The following is a description of a gene set: Human Gene Set: MIR548A_5P from publication Chen Y, Wang X (PMID 31504780) Genes predicted to be targets of miRBase v22 microRNA hsa-miR-548a-5p in miRDB v6.0 with MirTarget v4 prediction scores > 80 (high confidence targets). species: Homo sapiens, and this is the list of marker genes: HOXD13, DNAJB14, DENND1B, RRAGD, ACBD5 (NCBI Gene Id 91452), DHRS1, ZNF608, NOS2, FRMD5, ZDHHC2 (zinc finger DHHC-type palmitoyltransferase 2), PSMC2, TNFRSF21, PREX2, RASGRP1, KLRD1, ZBTB25, HOMER1, THSD7A, PPEF2, RO60, SLU7, ETF1, TTC19, DCDC2, MAML1, SNAP91, CCSER1, MTF1, BTG3, TFAM, RHPN2, ZBTB11, ACAT2, EEA1, MMD, LIN7A, CFDP1, IKBIP, PLEKHH2, ARK2N, ANKRD26, MED6, GULP1 (NCBI Gene Id 51454), SPAG9, FGL2, CCDC117, TMEM200A, GLIPR1, ZNG1F, PDCD5, DTWD2, U2SURP, A1CF, SOX5, CAPN2, CMPK2, SEC24A, AFTPH, CACUL1, ABCA5, LRP1B, AQP3, GPC6, LANCL1, MEX3D, GRIP1, FGF12, TMEM255A, TMEM135, ADAM22, PAX5, FOXG1 (forkhead box G1), NUP54, LATS1, ZNF454, GABRA4, GPD2, IGF1, FZD7, ZNF747 (zinc finger protein 747), MECP2, AGTR1, LARP4, PPP5C, PAQR9, RGPD6, MMP16, ZNF486, ZC3HAV1L, HOOK3, CTNNA3, LACTB2, EPB41L5, EDIL3, MARCHF6, RIMOC1, SFT2D1, TOLLIP, ADAM30 (ADAM metallopeptidase domain 30), HMBOX1, SCAMP1, FYB2, ACVR2B, ACTN4, ITGAV, ODAPH, LRRC7, HNRNPDL, RAB8B, RICTOR, ME1, EXOC5, SAMD8, TXLNG (NCBI Gene Id 55787), PDE1C, B3GALT5, PROK2, METTL6, DUSP7, PRKAG2, CACNA2D3, NR2C1, TRIM9, PRKAA2, SERINC5, MAST3, SRSF3, ATXN7L1, LPP, NDFIP2, CERS6, FGD4, BRWD1, ARFRP1, TMEM65, GCC2, CCDC47, GABPA, CAMLG, TRA2B, CCDC179, UGDH, BBS10, CAMSAP2, SSR3, MDFIC, CLVS2, PRKG1, ERC2, GTF3C3, KCNJ3, RHOQ, URI1 (NCBI Gene Id 8725), TP53INP1, SUMF1, ANKRD46, SIX4, DIAPH3, COL11A1, CEP120, ZBTB20, RNF138, FLRT3, ZNG1E, ZNF326, RBBP8, BTF3L4, PGAM1, KL, CHN1, SPATA6L, SMAD9, WDR7, NUP160, SACS, TRPC5, CSNK1D, C9orf40, UGT8, ZEB2, C21orf91, CCDC50, FAM133A, RC3H1, ELL2, TPM3, RAP1A, RNF149, IGF2BP3, GRID2, MFSD8, OAZ1, BOD1L1, MAP9, PRKAA1, ARMCX3 (armadillo repeat containing X-linked 3), LCOR, ZBTB44, DUS4L, NCKAP1, DPH6, NFKB1, ZRANB2, ZNF148, TMTC1, RORA, SECISBP2L, SESTD1, DEFA6, CHST9, NAA30, SENP1, SRSF6, ZFAND5, APPBP2, CBFB, SPDYE1, LVRN, DYNC1I2, MBNL3, RASSF8, NDC1, ADH5, SREK1, YIPF5, ARL6IP6, TLCD4, SPOCK3, GAPVD1, SNX16, RNF217, FMNL2, MEIS2, HECA, CCNY, HTR2C (NCBI Gene Id 3358), SRP9, AP1AR, HLTF, PRRC1, PRPF39, CLDN12, ZNF559, RGPD4 (RANBP2 like and GRIP domain containing 4), CNTN1, STXBP5, AK3, SANBR, MBNL2, ASB3, KRT28, ATP11A, LCTL, MAST4, GRM5, ZDHHC15, SCN8A (sodium voltage-gated channel alpha subunit 8), ZDHHC21, MMUT, TCF12, PDE4D, DNAJB4, PAPOLG, MAGT1, FNIP2, ZBTB10, ZNF492, DOLPP1, PCLO (NCBI Gene Id 56630), GOPC, RPS6KA5, SLC24A3, MINDY2, SLC4A7, NTF3, FBXL3, STYX, CRIPT, HDAC9, CLCN4 (NCBI Gene Id 4412), CHRNA7, TRUB1, ZNG1B, ACADL, RGS7BP, MTA1 (NCBI Gene Id 9112), ALG11, JARID2, NRG4 (NCBI Gene Id 145957), TMED7, LRRC4B, SERINC3, BNIP3, CD163, MCF2L2, ANGEL2, GUCY1B1, PCDH11Y, MYCN, PRPF40A, ITGB6, TFDP3, PGRMC2, RGPD8, AFDN, PTGFRN, ARID2, DAAM1, PTPRG, SAMTOR, LMCD1 (NCBI Gene Id 29995), HIPK1, GASK1A, GPATCH11, TMEM167B, IGSF3, FAM221A, GNAQ, SDE2, C3orf38, XPNPEP1, ADAMDEC1, GSTCD, SETD2, GPR155, BRWD3, NOTCH2, S1PR1, SLAIN1, RGPD5, TIFAB, CBX3, PPARG, ADGRB3, GABPB1, ZNG1A, AIDA, GRM7, C6orf120, TMTC3, TRPC1, CSGALNACT2, NAT1, IKZF2, ANAPC1, NAV2, UEVLD, PPP1R2, SLCO5A1, PTBP3, GPR85, PIWIL3, CCP110, ZBTB41, FNDC3B, FEM1C, RAB27B, UTP3, CDK6, LACTB, MGARP, ACBD3, DYNC1LI2, MAP4K4, MIDEAS, CD99, UNC80, KLF7, ARL13B (ADP ribosylation factor like GTPase 13B), NFAT5, C5orf24, PRP4K, ATXN2, FZD3, EPHA3, CCNB1, NOTUM, KIF20B, BTG2, NEDD4L, CEP350, NUMB, COMMD3-BMI1, STEAP2, SEC22C, ANKRD22, METTL8, FIGN, RAP2A, NUP50, RIC1, MIER1 (NCBI Gene Id 57708), SCN3A, PRELID2, FSBP, SLC30A5, CFAP44, EIF2AK2, BEND7, CFL2, SDC2, BBX, SCARF1, GOLGA6L2, TRAM1, AHSA2P, RALA, SKIDA1, NRXN1, TBCA, ZNF680, POLR2H, TMEFF2, BCL2L2, ZNF792, ANKRD10, KLF10, RMND5A, PROSER1, PLEKHG1, C11orf87, SCN1A, CARF (NCBI Gene Id 95855), FGFR1OP2, MBIP, MIGA1, SF3A1, MIER3, GCNT1, CIAO2A, SMAD5, SNX30, PDZRN4, PITX2, WDR47, RESF1, SYTL5, ZCCHC8, FAM199X, CRACD, KIAA1586, RETREG1, CYBRD1, SCML2, LSAMP, ADAMTS1, BMI1, SFMBT1, CISD2, KLF8, RFX7, PTPRR, ABI3BP, REV3L, PCDH11X, MFN1 (mitofusin 1), PPHLN1, TBCK, SH3D19, ZNF503, ZNG1C, LRRTM3, GSE1, NEGR1, DDIT4, ARRDC4, RFC3, KATNBL1, TTC13, UBA6, MZT1, WAPL, KPNA4, FAM135A, EVI2A, DIP2B, CCNG2, GATM, SDF4, TRIM2, SMG1, FZD5, DPY19L3, WDR26 (WD repeat domain 26), GUCY1A2, MTFR1, PPP1R9A, LMX1A, UBE2A, ZNF652, SYNM, OGFRL1, PPP1R27, CA8, GPALPP1, PHYHIPL